The following is a description of a gene set: The directed movement of copper cation across a membrane. Human Gene Set: GOBP_COPPER_ION_TRANSMEMBRANE_TRANSPORT studied in species Homo sapiens, and this is the list of marker genes: ATOX1, SLC46A3, SLC31A1, SLC31A2, SLC39A11, ATP7B, STEAP2 (NCBI Gene Id 50630), SLC11A2, ATP7A